Given this list of marker genes ZNF252P, PLA2G4F, SLPI, RFT1, PLAAT4 (NCBI Gene Id 5920), GBP3, DNAH17, B3GALT4, MNT, FHL1P1, RNU4-80P, SLC12A2, METTL17, RPS6KB2-AS1, JMJD7, SAA1, A4GALT (alpha 1,4-galactosyltransferase (P1PK blood group)), CTU2, PUSL1, USP21, ARHGAP23P1, POLR2J4, NR2F6, GPR108, PP2D1, NDUFB2-AS1, ANKRD35, SPRR1B, LYSET, GARIN5A, LYPD2, SLC35C1, RPL13AP20, APOBEC3F, ADCK2, DMRTA2, BCL2L2, SEH1L, ELMOD2, SLC52A3, MIS12, LTV1, LINC03073, SMIM5, KRT39, TSPAN6, PFKFB3-AS1, TM9SF2, H2AJ, CLDN8, SNORA81, SRP68, LYRM4-AS1, CAPN5 (NCBI Gene Id 7445), ENSG00000267174, POLR2J3, TMEM125, GPC1-AS1, TMEM191A, CLDN4, TMEM11, NANP, PHOSPHO2, EXOC8, AQP5-AS1, UMODL1, DHRS9, ENSG00000263765, RAB1B, NOL6, NSUN2, MYCL, CMPK1, PPP1R14D, SLC15A2, CCL28, TMEM216, TLR5 (toll like receptor 5), SDR16C5 (short chain dehydrogenase/reductase family 16C member 5), CX3CL1, C19orf73, ZDHHC13, DUSP5, TMEM258, DMAP1, RPL37P6, DTX4, RNU5A-1, MMEL1, NACA3P, GPR87 (NCBI Gene Id 53836), INSIG1-DT, FAM3D, SHLD2P1, VTCN1, MALL, TWF1, GGCTP1, BNIP1, CDKN2B (NCBI Gene Id 1030), TSC22D3, FOXD2-AS1, HS3ST6, NIF3L1, NKAPL, ENSG00000236064, UPK1B, COMMD4, BAG1, CCDC28A, MRPL13, BMI1, SPINT1, CHMP2A (charged multivesicular body protein 2A), SEMA3E, QARS1 (glutaminyl-tRNA synthetase 1), EMC4, PHKG2, MMP7, CFAP418, DHX38, ESF1 (NCBI Gene Id 55639), CHI3L1, C14orf28, RNASEL (NCBI Gene Id 6041), ZNF766, AGTRAP, FAM171B, MED24 (NCBI Gene Id 9862), LYSMD1, CRB3, IGIP, ZNF681, FAM86C1P, RN7SL118P, CXCL17, ZNF526, TEPSIN, ASPG, SUPT7L, TIMM29, GXYLT1, LINC01269, SLC24A3-AS1, NFKBIB, NR4A1, TNFSF15, TRIM22, LIPT2, KRT12, GABRP, RHOV, ATP6V1G1, GGT6, SPRTN, ZNF629, PRRT3, CNFN, ZNF674, SKP1, TET2-AS1, TMEM127, ZNF182, DSC3, LINC02194, B4GALT5, HSD17B1-AS1 (HSD17B1 antisense RNA 1), EFCAB15P, FBXL6, GJB2, MUC22, MESP1, ALOX5, S100A9, PSMD14-DT, NKX3-1, HMGN2P5, IRF5, PLEKHS1, KRT4, TMEM139-AS1, LINC01931, DSG1, BBOX1, FUT2, ZIK1, BACH1-IT3, CAPNS2 (calpain small subunit 2), NXT1 (nuclear transport factor 2 like export factor 1), NHP2, KDF1 (keratinocyte differentiation factor 1), CDKN2A, SLC16A13 (NCBI Gene Id 201232), RARRES1, GTF2H5, COIL, LCN2, COPG1, MPZL2, CYP2R1, CXCL1, S100A8, TIGD1, SPINT2, ZSCAN25, SERPINB1, MUC16, RNPEPL1, STAT2, EXO5, ATP13A1, VNN2, RPS29P11, ZG16B, OAZ3, HCAR2 (hydroxycarboxylic acid receptor 2), ZNF793-AS1, ZFP42, TPPP, SLC34A2, DELEC1, ENSG00000268833, RAB25, RPL12P4, PIGR, ZNF879, ENO1P1, GALNT5, LINC02361, AGGF1, DCTN6, ZNF689, CYP2F1, LRP10, DAZAP2, DNAJC19, PRSS22 (NCBI Gene Id 64063), FAM186A, DTX3L (NCBI Gene Id 151636), MHENCR, OTX1, C1orf116, PSME2, ENSG00000237773, CASP7, MTRF1L, RPL13AP2, MUC4, KLF4, FIBP (FGF1 intracellular binding protein), NR4A2, CD2BP2, LINC01770, JDP2, SYNGR2, ZNF454, ATP6V0C, APOBEC3A, CXCL8, SPCS1, METTL13, STEAP4, DYM-AS1, U2AF1L4, CALML5, ZDHHC12, EDRF1-DT (NCBI Gene Id 399821), ABHD11, MRM2, BATF, PEX11B, NDUFS5P1, SPATA2, IER3IP1, ENSG00000124835, ZNF576, TACSTD2, PLPP6, SRD5A3, VPS37C (VPS37C subunit of ESCRT-I), FAM83H, ALG1L1P, MIER2, NUP85, PBX2, FAM83A, HDAC11, CEACAM7, CEACAM6, TRAM1L1, RNU4-1, LINC00342, NOXO1 (NADPH oxidase organizer 1), TCHP, here is a description of the gene set: The gene expression program underlying the specification of human cell types is of fundamental interest. The study authors generated human cell atlases of gene expression and chromatin accessibility in fetal tissues. For gene expression, the study authors applied three-level combinatorial indexing to >110 samples representing 15 organs, ultimately profiling ~4 million single cells. The study authors leveraged the literature and other atlases to identify and annotate hundreds of cell types and subtypes, both within and across tissues. Our analyses focused on organ-specific specializations of broadly distributed cell types (such as blood, endothelial, and epithelial), sites of fetal erythropoiesis (which notably included the adrenal gland), and integration with mouse developmental atlases (such as conserved specification of blood cells). These data represent a rich resource for the exploration of in vivo human gene expression in diverse tissues and cell types. Marker genes curated from the annotated cluster as represented in the Descartes Human Gene Expression During Development database. from publication Cao J, O'Day DR, Pliner HA, Kingsley PD, Deng M, Daza RM, Zager MA, Aldinger KA, Blecher-Gonen R, Zhang F, Spielmann M, Palis J, Doherty D, Steemers FJ, Glass IA, Trapnell C, Shendure J (PMID 33184181) Human Gene Set: DESCARTES_MAIN_FETAL_CORNEAL_AND_CONJUNCTIVAL_EPITHELIAL_CELLS species: Homo sapiens